The following is a description of a gene set: The portion of the plasma membrane surrounding a stereocilium. studied in species Mus musculus Mouse Gene Set: GOCC_STEREOCILIUM_MEMBRANE, and this is the list of marker genes: Adgrv1, Myo1c, Pkhd1l1, Vezt, Mcoln3, Ush2a, Clrn2, Ripor2